The following is a description of a gene set: from publication Amit I, Garber M, Chevrier N, Leite AP, Donner Y, Eisenhaure T, Guttman M, Grenier JK, Li W, Zuk O, Schubert LA, Birditt B, Shay T, Goren A, Zhang X, Smith Z, Deering R, McDonald RC, Cabili M, Bernstein BE, Rinn JL, Meissner A, Root DE, Hacohen N, Regev A (PMID 19729616) mouse primary BMDCs were stimulated with tlr ligands and gene expression changes were profiled on Affymetrix arrays Genes up-regulated in comparison of dendritic cells (DC) stimulated with Pam3Csk4 (TLR1/2 agonist) at 8 h versus DC cells stimulated with Gardiquimod (TLR7 agonist) at 8 h. Human Gene Set: GSE17721_PAM3CSK4_VS_GADIQUIMOD_8H_BMDC_UP species: Homo sapiens, and this is the list of marker genes: ETFRF1, ATP13A2, CLCN4, PHYKPL, ANXA2, OLA1, CD1D, RPL13A, C1GALT1, CHORDC1, EHBP1, PDCD2, ARPP19, GTPBP4, ASCL2, ACOT7, SPAG5, GNB2, NEAT1, HERC1 (NCBI Gene Id 8925), SLC10A6, ALDH9A1, AHCYL1, LAMTOR3, CALU, RPF2, TAF9, KLHL36, CDHR1, IFRD2, NDUFA5, SRXN1, MRPS11, FASN, FASTKD2, IDH3G, ATP5MC2, KCNAB2, ANTKMT, PAICS, RAB33A, AIFM1, GOT2, NFE2L3, GYS1, NUFIP1, NUP188, COPS5 (NCBI Gene Id 10987), PSME3, MRPL52, RETREG1, UBE2G2, TXNRD2 (NCBI Gene Id 10587), SEC24D, CLPP, LMAN1, NUDC, EIF3A, COA6, EBI3, SACS, TMEM184C, PLEC, PSMD6, EVI5, DOCK1, AKIP1, FERRY3, STARD4, TMEM268, SMYD2, ALAD, PAFAH2, LPGAT1, UQCRFS1, EMILIN1, FBXO33, EEF1AKMT1, GPAM, AK1, HACD2, MTREX, RPP14, DNAJC5, EIF2B5, TPRA1, HES1, NOL12, SLC25A13, XPO5, RGS19, FBXO31, GGH (NCBI Gene Id 8836), TRMT1, FADS1, CEP95, RPL14, GSS, ARPC1A (NCBI Gene Id 10552), IMPDH2, UBALD1, PSMA7, FUCA2, FAM89B, UPF1, MYADM, PWP2, DHRS7, EXOSC10, CAMK1D (calcium/calmodulin dependent protein kinase ID), ZDHHC16, HOXB6, SRSF6 (NCBI Gene Id 6431), GTF2F2, GLRX3, CD80, ITGB1BP1, SARAF, NRG4 (NCBI Gene Id 145957), CCT2, ST6GAL1, SPSB3, CRISP2, PWP1, MIEN1, UBAP2, EMC7, MRRF, HVCN1, NDST4, NBEAL2, NOCT, TARS2, INTS6L, PAQR7, PDIA6, RTL8C (NCBI Gene Id 8933), METTL3, PDXDC1, AQP4, NXT1, CDH23, HERPUD1 (NCBI Gene Id 9709), APRT, CLMP, TKT, PCLO, PHKA2, CPSF3, SMC3, GPR155, IQSEC1, NR4A1, ZNF706, PYCR2, ATP5F1C, CAMKV, TNFRSF19, COMTD1, KLF7, CCDC65, MRPL41 (NCBI Gene Id 64975), TFEC, EID1, TMEM35A, RPS6KA4, RBBP7, MCM7, PSEN1 (presenilin 1, NCBI Gene Id 5663), SLC66A2, ODR4, PLD3, MCOLN2, FBP1, DPEP3, BDH1, RWDD3, ATP5MC1, RAD17, CNIH1, SLC35A2, C8orf76, CTC1, SLC20A1, COX19, EPRS1, CDK2AP1, SLC11A1, BBLN, SS18, PTTG1IP, DNAJC2, NDUFB10, RPS11 (ribosomal protein S11), SASH3 (NCBI Gene Id 93952), POLR2G, KRT13, TIMM8A, UBXN4